Given this list of marker genes Sct, Irs1, Cckbr, Cartpt, Ffar4, Cckar, Npff, Cacna1e, Adcyap1, here is a description of the gene set: The regulated release of somatostatin from secretory granules in the D cells of the pancreas. studied in species Mus musculus Mouse Gene Set: GOBP_SOMATOSTATIN_SECRETION